The following is a description of a gene set: studied in species Mus musculus Mouse Gene Set: GOBP_MICROTUBULE_CYTOSKELETON_ORGANIZATION_INVOLVED_IN_MITOSIS Any microtubule cytoskeleton organization that is involved in mitosis., and this is the list of marker genes: Clasp1, Smc1a, Drg1, Abraxas1, Chmp1b (NCBI Gene Id 67064), Efhc1, Stil (NCBI Gene Id 230631), Dlgap5, Nsfl1c, Pibf1, Mzt1, Htt, Ccdc66, Poc1a, Tpx2, Pafah1b1, Plk3, Golga2, Pkhd1, Ilk, Cdk5rap2, Fam110a, Ints13, Kif3b, Cenpa, Stag1, Chek2, Cenpe, Cep126, Psrc1, Stag2, Tacc2, Fsd1, Racgap1, Enkd1, Mybl2, Rab11a, Chmp2a, Rae1, Zw10, Aurka, Hnrnpu, Cep97, Kif4, Ccsap, Map10, Ofd1, Zfp207, Ankrd53, Ndc80, Dync1h1, Ankfn1, Mcph1, Kif15, Uhrf1, Misp, Cenph, Flna, Prickle1, Poldip2, Tubg2, Nde1, Cenpj, Wrap73, Kif23, Bora, Chmp1a, Nusap1, Mapre1, Ccdc61, Eml3, Stmn1, Mad2l1, Fbxw11, Tbce, Kifc5b, Nek2, Aurkb, Ptpa, Hspa1a, Bccip, Pax6, Cep192, Nup62, Fgf10, Birc5, Gpsm1, Aaas, Tubg1, Spc25, Dctn2, Clasp2, Kat5 (K(lysine) acetyltransferase 5), Vcp, Afg2b, Sbds, Dynlt1b, Setd2, Ubxn2b, Ckap5, Nuf2, Chmp4c, Pkd1, Sass6, Cltc, Plk1, Chmp4b, Cdc20, Prc1, Smc3, Kif11, Tpr (NCBI Gene Id 74816), Snhg15, Plk2, Map9, Plk5, Arhgef10 (Rho guanine nucleotide exchange factor 10), Spry1, Dctn6, Chmp5, Itgb1, Ndel1, Chmp3, Kifc1, Rhoa, Chmp6, Spdl1, Ccnb1-ps, Vps4b, Hspa1b, Spice1, Khdc3, Cdk1, Aurkc, Ccnb1, Spry2, Nudc, Ripor2, Gnai1, Abraxas2, Gja1, Map4, Wdr62, Rangrf, Parp3, Inppl1, Rcc1, Lsm14a, Dctn1, Sapcd2, Chmp2b, Kif2a, Cdca8, Arhgef2, Eml1, Pcnt, Numa1, Tacc3, Kpnb1, Tacc1, Spast, Map1s, Incenp, Chmp1b2, Chmp7, Gpsm2, Hdac3